Given this list of marker genes CWC25, CASC3, RBM22, CWC22, PRPF8, MAGOHB, PRPF19, YJU2, EIF4A3, SNRNP200, ISY1, RBM8A, here is a description of the gene set: Human Gene Set: GOCC_CATALYTIC_STEP_1_SPLICEOSOME A spliceosomal complex that is formed by the displacement of the two snRNPs from the precatalytic spliceosome; three snRNPs including U5 remain associated with the mRNA. This complex, sometimes called the activated spliceosome, is the catalytically active form of the spliceosome, and includes many proteins in addition to those found in the associated snRNPs. species: Homo sapiens